The following is a description of a gene set: Human Gene Set: GOMF_NEUROTROPHIN_TRK_RECEPTOR_BINDING Binding to a neurotrophin TRK receptor. studied in species Homo sapiens, and this is the list of marker genes: PLCG1, SHC1, PIK3R1, GRB2, EFNA5, FRS2